Given this list of marker genes GPC3, GPC4, FGFR3, TRPV4, SLC26A2, COL2A1, here is a description of the gene set: Short greater sciatic notch species: Homo sapiens The sacroiliac joint in the bony pelvis connects the sacrum and the ilium of the pelvis, which are joined by strong ligaments. The notch is located directly superior to the joint. This term refers to a reduction in the height of the notch. Human Gene Set: HP_SHORT_GREATER_SCIATIC_NOTCH